The following is a description of a gene set: Genes up-regulated in peripheral blood mononuclear cell stimulated vs unstimulated in adults (37-48) after exposure to HIV-LIPO-5, time point 14W. Comment: Genes that act in the interferon pathway studied in species Homo sapiens from publication Richert L, Hue S, Hocini H, Raimbault M, Lacabaratz C, Surenaud M, Wiedemann A, Tisserand P, Durier C, Salmon D, Lelièvre JD, Chêne G, Thiébaut R, Lévy Y, ANRS Vaccine Network/Vaccine Research Institute (PMID 23759749) Human Gene Set: RICHERT_PBMC_HIV_LIPO_5_AGE_37_48YO_STIMULATED_VS_UNSTIMULATED_14W_INTERFERON_SUBSET_UP OBJECTIVE: To dissect the biological mechanisms involved in the cellular responses to a candidate vaccine containing 5 HIV peptides coupled to a palmytoil tail (HIV-LIPO-5) in healthy volunteers, by using extensive immunogenicity assessments with different stimulation durations. DESIGN: Immunogenicity substudy of a randomized phase II prophylactic HIV vaccine trial (ANRS VAC 18). METHODS: HIV-LIPO-5 or placebo was administered at W0, W4, W12 and W24. Peripheral blood mononuclear cells from a subset of participants at W0 and W14 were stimulated with HIV-LIPO-5, Gag peptides contained in the vaccine and control peptides. ELISpot, lymphoproliferation, intracellular cytokine staining (ICS), cytokine multiplex and transcriptomic analyses were performed. Different time points and stimulation conditions were compared, controlling for test multiplicity. RESULTS: Cultured ELISpot and lymphoproliferation responses were detected at W14. Ex-vivo ICS showed mainly interleukin (IL)-2-producing cells. Secretion of interferon (IFN)-gamma, tumour necrosis factor (TNF)-alpha, IL-5 and IL-13 increased significantly after culture and Gag stimulation at W14 compared to W0. Metallothionein genes were consistently overexpressed after HIV-LIPO-5 stimulation at W0 and W14. At W14, significant probes increased substantially, including IFN-gamma, CXCL9, IL2RA, TNFAIP6, CCL3L1 and IL-6. Canonical pathway analyses indicated a role of interferon signalling genes in response to HIV-LIPO-5. CONCLUSION: HIV-LIPO-5 vaccination elicited Th1 and Th2 memory precursor responses and a consistent modulation in gene expression. The response profile before vaccination suggests an adjuvant effect of the lipid tail of HIV-LIPO-5. Our combined immunogenicity analyses allowed to identify a specific signature profile of HIV-LIPO-5 and indicate that HIV-LIPO-5 could be further developed as a prime in heterologous prime-boost strategies., and this is the list of marker genes: IFNG, SOCS1, TAP1, STAT1, IFI35